The following is a description of a gene set: species: Mus musculus Mouse Gene Set: GOBP_CEREBRAL_CORTEX_RADIALLY_ORIENTED_CELL_MIGRATION The migration of cells in the developing cerebral cortex in which cells move from the ventricular and/or subventricular zone toward the surface of the brain., and this is the list of marker genes: Pou3f3, Reln, Cdk5r2, Col3a1, Adgrg1, Rac1, Wdr47, Srgap2, Foxg1, Dixdc1, Zmiz1, Dab1, Rtn4, Gli3, Ctnnb1, Cdk5, Pafah1b1, Nr2e1, Rnf7, Mdga1, Pou3f2, Dab2ip, Ndel1, Ulk4, Socs7, Ccdc141, Fbxo45, Lamb1, Sun2, Bmerb1, Sun1, Lhx6, Cul5, Cdk5r1, Dcx, Mboat7, P2ry12, Disc1, Syne2, Fut10, Lrp8